The following is a description of a gene set: from publication Abbas AR, Baldwin D, Ma Y, Ouyang W, Gurney A, Martin F, Fong S, van Lookeren Campagne M, Godowski P, Williams PM, Chan AC, Clark HF (PMID 15789058) Genes down-regulated in comparison of naive CD8 T cells versus naive B cells. Human Gene Set: GSE22886_CD8_TCELL_VS_BCELL_NAIVE_DN studied in species Homo sapiens Immune cell-specific expression is one indication of the importance of a gene's role in the immune response. In order to identify such patterns, we set out to broadly profile gene expression in a variety of immune cells., and this is the list of marker genes: IFNA4, DTX4, FADS3, PTGS1, SLC6A16, NOD1, RDH8, FRAS1, CR2, MIR600HG, TRIM25 (tripartite motif containing 25), RAB30, MTCL2, HLA-DPA1, ENTPD1, CD80, TSHB, CTNNAL1, CNKSR2, LALBA, RPS27, ZNF682, TOMM34, PRR3, CLEC4A, SAMD4A, KMO, BLNK, FZD4, TIMELESS (NCBI Gene Id 8914), TREML2, PKIG, SOBP (sine oculis binding protein homolog), TCL1A, CD22, PIP5K1A, HLA-DMA, LHFPL2, LARGE1, HLA-DPB1, GPM6A, IL1R1, BANK1, SLC25A16, CDK19, MYOZ3, APOL5, MEF2C, SCD5, NAB1, CNR1, SLC4A4, MAGEA4, HLA-DRB6, MTMR10, TNS3, PAPSS2, PLPP3 (phospholipid phosphatase 3), BTK, SBNO1, ZC2HC1A, SLC7A7, GSTA1, STAP1, PLCG2, MED14OS, PRPH2, RASL12, EGR2, APCS, HIF1AN, BACE2 (beta-secretase 2), IRF8, CHL1, SLC9A7, SELENBP1, SNX29, GABBR1 (NCBI Gene Id 2550), LRRC19, CTSK, RIC3, POU6F1, MS4A1, SMPX, ADAM19, RIPOR1, TBC1D30, SPIB, HILPDA, SLC15A3, TNFAIP1, LAMC1, DPF3, FMO5, PEG10, STRN3, RHD, MID1, PAWR, FAM30A, DRAM1, KYNU, CCDC170, BCL7A, SEMA4F, TCF4, FZD10, ATP6V0A1, DLG5, IL24, PCDHGA10, MYOF, GAB2, CDK14, KLK2, PTPRK, SMR3B, GTPBP3, FBXO4, HHEX, DNASE1L3, MPZL1, BCL11A, CYP51A1, IDI2-AS1, CYP2A7P1, CD72, PARM1, GRK3, FCGR2A, HDAC9, KATNBL1, TSPYL5, CYSLTR1, DUSP6, SYK, ZNF112, CTNNA1, DDR1, SH2B2, HAUS5, TCL6, SP1, HLA-DMB, REPS2, SLC2A5, DNMBP, ZNF532, SFN, DCAF17, IGHD, ACSL6, TSPAN13, IL4R, HLA-DRB1, HEYL, RAB11FIP3, TAF4B, RBM4B, PHF7, BCL2L2, ARHGAP32, CHAT, APP, MYO1B, CD19, CEP43, TTC28, LY86 (NCBI Gene Id 9450), GATM, CLCN4, HMGCS1, ISL1, KCNJ2, IFNA7, POLR1HASP, TBC1D12, USP2, RASL10A, SPRY4, ATP11A, MAS1 (NCBI Gene Id 4142), SMAD5, TLR6, HMGB3P1, PHLPP2, GSTA4, CD180, CD83, FOLH1B, PDE10A, CD200, HLA-DRA, HLA-DOB, VAV2, CORO2B, P2RX1, PIP5K1B